Given this list of marker genes OASL, JAK2, MAX, CLIC4, CGGBP1, IFNG, MYH10, DHX40, TGFB3, PRRG4, ATF3, ST3GAL6, PDCD1, RIPK1, TMEM219, TRIM26, HSH2D, GIMAP4 (NCBI Gene Id 55303), GCH1, AXL, OLAH, TAF7, CEP15, GTF2A1, MPP1, PAFAH1B2, TTC4, ARID5A, MAD1L1, HNRNPH2, FAM3C, TMEM184B, CGAS, SPG7, ELOA, TRIM14, MLKL, DUSP10, GSDMD, CFAP210, TOM1L2, ZNFX1, ENPP4, RARS1, FAM89A, ALDH7A1, KANSL1L, ZNF207, PLAUR, STON2, IKZF2, EMC8, DDX4, PTPRO, STAT2, LRP8, GRAMD2B, POU6F1, MAPK6, POLR2C, CPEB4, HDAC1, RFWD3, UBC, CCRL2, GPR15, IL1RAP, KDM6B, PPIF, DNAJC7, UBA7, RAB1A, SLC7A3, CD200R1L, CH25H, TIPARP, SMIM3, PDZD8, LTA, CD274, IL6, TNF, ASB13, UBALD2, PGAM2, SH3BP2, CCL5, ELL3, MITD1, MLLT3, ITGA4, RFC3, THEMIS2, USP12, DPPA2, PLAAT3, PPFIBP1, MACIR, SYNPO2L, RASGEF1B, TRA2A, HSPA5, POLM, GSAP, OTUD1 (NCBI Gene Id 220213), BLZF1, ZBTB5, GLIPR1, ALCAM, MTHFS, CARMIL1, FZD5, CXCL11, CD40, TENT5C, JAM3, SETD4, TSPO, CACNB2, ARHGEF3, NSD3, PLXNC1, TSPAN31, TRIB1, SETDB2, PIGV, ABCB1, MVP, SELENOK, OPTN, TNFSF10, PLEKHA2, SLC25A22 (solute carrier family 25 member 22), PPA1, SOWAHC, ARL14, C11orf68, GPR85, LYST, CCND2, ZNF710, AGRN, NFKBIZ, FAM162B, HSDL2 (hydroxysteroid dehydrogenase like 2), IFNA1, TNFSF9, ANGPT1, DTX3L, TREML2, C19orf12, ZNF516, VPS54, TMOD3, STXBP3, MACC1, ARMCX2, RBL1, PML, RIGI, TAF6L, CSRNP1, TMED5, IL12B, INPP1, RHOG, ACOT9, PARP11, TRAF1, RNF139, CDHR5, MAP10, GTF2E2, MYCBP2, SIRT1, GBP2, ISOC1, TAPBP, PI4K2A, KAT6A, SAT1, VIM, ZBTB16, TIMELESS, HEATR5B, MTMR11, MAP3K5, INTS8, RAB5IF, APOOL (apolipoprotein O like), TAGAP, PPM1K, FRMD4A, PHKA2, KATNA1, CCNYL1, NDEL1, SPRED1, TRIM34, SEMA6D, here is a description of the gene set: from publication Ochiai K, Maienschein-Cline M, Simonetti G, Chen J, Rosenthal R, Brink R, Chong AS, Klein U, Dinner AR, Singh H, Sciammas R (PMID 23684984) Human Gene Set: GSE46606_DAY1_VS_DAY3_CD40L_IL2_IL5_STIMULATED_IRF4HIGH_BCELL_DN Temporal analysis of B cell activation in vitro using CD40L and IL-2/4/5 cytokines in wild type Irf4+/+ B cells or in mutant Irf4-/- B cells harboring a tet-inducible allele of Irf4. IRF4 expression was restored, or not, in the Irf4-/- background by culturing in the presence of low or high concentrations of doxycycline. The results provide insight in the role of IRF4 expression levels in coordinating different programs of B cell differentiation. studied in species Homo sapiens Genes down-regulated in CD40L and IL-2 IL-4 IL-5 stimulated at day 1 B cell IRF4high versus CD40L and IL-2 IL-4 IL-5 stimulated at day 3 B cell IRF4high.